The following is a description of a gene set: studied in species Homo sapiens Human Gene Set: REACTOME_SIGNALING_BY_NOTCH4 Signaling by NOTCH4, and this is the list of marker genes: EP300, ADRM1, KAT2A, HEY2, PSMB3 (proteasome 20S subunit beta 3), PSMA6, PSEN1, APH1B, PSMC5, MAML1, FLT4, PSMD13, DLL4, PSMC4, PSMA1, RPS27A, PSMA3, FBXW7, PSMA7, PSMB2, APH1A, PSENEN, ADAM10, PSMA5, CREBBP, TACC3, PSMD7, HEY1, PSMD1, RBPJ, JAG1, UBC, UBA52, NCSTN, HES1, PSMD11, PSMC3, NOTCH1, SKP1, PSMD3 (NCBI Gene Id 94019), RBX1, PSEN2, NOTCH2, PSMD14, MAMLD1, PSMB4, PSMD6, PSMB5 (proteasome 20S subunit beta 5), PSMB1, ACTA2, PSMA2, SEM1, CUL1, HES5, PSMC1, YWHAZ, PSMD8, MAML2, AKT1, UBB, SMAD3, MAML3, NOTCH4, PSMA4, PSMD12, PSMC6, PSMB7, PSMB6, PSMD2, KAT2B, SNW1, PSMC2